Given this list of marker genes TOPBP1, PRKDC, HELQ, HMCES, NBN, POLQ, LIG3, PLK1, RHNO1, here is a description of the gene set: An instance of double-strand break repair via nonhomologous end joining that is independent of factors important for V(D)J recombination (as opposed to classical nonhomologous end joining). It often results in a deletion with microhomology (i.e. 5-25bp homology) at the repair junction. Among different subclasses of nonhomologous end joining (NHEJ), alternative NHEJ appears to play a significant role in the etiology of mutations that arise during cancer development and treatment. studied in species Homo sapiens Human Gene Set: GOBP_DOUBLE_STRAND_BREAK_REPAIR_VIA_ALTERNATIVE_NONHOMOLOGOUS_END_JOINING